Given this list of marker genes PRKACB, IGKV1D-13, PDCD4, SNX2, GVINP1, CKAP2, RRAS2, IL24, PAX5, CHMP7, PDLIM1, FCHSD2, BLK, IL2RG, ISCA1, RBM26, HLA-DOB, LBH, ADD3, SMAGP, CD200, FCRL2 (NCBI Gene Id 79368), PHF3, TSC2, GPR18, GGA2, IGKC, DDHD2, NPM1, OSBPL10, SIPA1L3, CD22, ODC1, TCF3, NSUN5, RABEP1, PIM2, CD72, BIRC3, ADAM19, FCMR, RPS17P5, IGLL3P, SETBP1, ANKRD36, BARD1, CLEC2D, CD37, BIN1, CCR6, ZNF430, ABLIM1, BLNK, ZNF43, ITPR1, DENND5B, SYPL1, BACH2, KCNA3, RUBCNL, CD19, GABPB1, SIDT1, MS4A1, NUP88, SP110, SWAP70, ARHGEF18, CD79A, AQP3, TCL1A, RPS20, PHTF2, PTPRCAP, CD47, BCL11A, BTG1, IGLV1-44, CYFIP2, ZSCAN18, TPD52, ITM2A, CD69, WEE1, ZEB1, TSPAN13, RPS25, PKIA, FAM3C, BCL7A, SYNPO, MYC, PLEKHA2, DGKD, NCK2, DDX6, PRDM4, P2RX5, IL4R, SH3BP5, NGLY1, RPS6, IGLJ3, MAP4K1, CD79B, QRSL1, FCER2, PKIG, TNFAIP8, SEL1L3, E2F5, BANK1, CD24, RASGRP3, SPTBN1, SOX12, ZMYND8, KAT6A, GSDMB, DUS2, TENT5C, SRSF10, IFT57 (intraflagellar transport 57), ADAM28, RCN2, RPS5, MBD4, BACE2, PCDH9, IGHD, AEN, EAF2 (NCBI Gene Id 55840), FAM30A, TNFRSF13B, TRAF5, SLC50A1, RPL9, RPSA, ZHX2, TLE1, ATP2A3, PAIP2B, OGA, PIK3C2B, BMS1P20, SPOCK2, ATM, ETS1, IGHM, SMC3, SEPTIN6, ARGLU1, NCOA3, TRBC1, ABCB4, VPREB3, ARID4B, ANK3 (ankyrin 3), GUSBP11, CHD7, STAG3, STAP1 (NCBI Gene Id 26228), IKZF3, PLCG2, ZNF395, POU2AF1, IGKV3-20, SLC25A38, TRIB2, RAPGEF6, P2RY10, ZNF273, GOLGA8A, CCNB1IP1, LAMC1, PWP1, CDK14, COBLL1, SKAP1, TAF1D, CDC25B, ZNF253, EZR, GNG7, IGKV4-1 (immunoglobulin kappa variable 4-1), RASGRP1, NT5E, SAV1, RBBP6, SLC38A1, PPP1R16B, LINC00342, RHOH, SP140, PNOC, RPS23, here is a description of the gene set: Systems vaccinology has emerged as an interdisciplinary field that combines systems wide measurements and network and predictive modeling applied to vaccinology. Here we used the systems vaccinology approach to study the molecular mechanisms underlying th studied in species Homo sapiens Human Gene Set: GSE29618_BCELL_VS_MONOCYTE_DAY7_FLU_VACCINE_UP from publication Nakaya HI, Wrammert J, Lee EK, Racioppi L, Marie-Kunze S, Haining WN, Means AR, Kasturi SP, Khan N, Li GM, McCausland M, Kanchan V, Kokko KE, Li S, Elbein R, Mehta AK, Aderem A, Subbarao K, Ahmed R, Pulendran B (PMID 21743478) Genes up-regulated in comparison of B cells from influenza vaccinee at day 7 versus monocytes from influenza vaccinee at day 7.